The following is a description of a gene set: studied in species Homo sapiens part of: Innate Immune System Reactome Pathway: Fc epsilon receptor (FCERI) signaling Mast cells (MC) are distributed in tissues throughout the human body and have long been recognized as key cells of type I hypersensitivity reactions. They also play important roles in inflammatory and immediate allergic reactions. Activation through FCERI-bound antigen-specific IgE causes release of potent inflammatory mediators, such as histamine, proteases, chemotactic factors, cytokines and metabolites of arachidonic acid that act on the vasculature, smooth muscle, connective tissue, mucous glands and inflammatory cells (Borish & Joseph 1992, Amin 2012, Metcalfe et al. 1993). FCERI is a multimeric cell-surface receptor that binds the Fc fragment of IgE with high affinity. On mast cells and basophils FCERI exists as a tetrameric complex consisting of one alpha-chain, one beta-chain, and two disulfide-bonded gamma-chains, and on dendritic cells, Langerhans cells, macrophages, and eosinophils it exists as a trimeric complex with one alpha-chain and two disulfide-bonded gamma-chains. FCERI signaling in mast cells includes a network of signaling molecules and adaptor proteins. These molecules coordinate ultimately leading to effects on degranulation, eicosanoid production, and cytokine and chemokine production and cell migration and adhesion, growth and survival.<br>The first step in FCERI signaling is the phosphorylation of the tyrosine residues in the ITAM of both the beta and the gamma subunits of the FCERI by LYN, which is bound to the FCERI beta-chain. The phosphorylated ITAM then recruits the protein tyrosine kinase SYK (spleen tyrosine kinase) which then phosphorylates the adaptor protein LAT. Phosphorylated LAT (linker for activation of T cells) acts as a scaffolding protein and recruits other cytosolic adaptor molecules GRB2 (growth-factor-receptor-bound protein 2), GADS (GRB2-related adaptor protein), SHC (SRC homology 2 (SH2)-domain-containing transforming protein C) and SLP76 (SH2-domain-containing leukocyte protein of 76 kDa), as well as the exchange factors and adaptor molecules VAV and SOS (son of sevenless homologue), and the signalling enzyme phospholipase C gamma1 (PLC-gamma1). Tyrosoine phosphorylation of enzymes and adaptors, including VAV, SHC GRB2 and SOS stimulate small GTPases such as RAC, RAS and RAF. These pathways lead to activation of the ERK, JNK and p38 MAP kinases, histamine release and cytokine production. FCERI activation also triggers the phosphorylation of PLC-gamma which upon membrane localisation hydrolyse PIP2 to form IP3 and 1,2-diacylglycerol (DAG) - second messengers that release Ca2+ from internal stores and activate PKC, respectively. Degranulation or histamine release follows the activation of PLC-gamma and protein kinase C (PKC) and the increased mobilization of calcium (Ca2+). Receptor aggregation also results in the phosphorylation of adaptor protein NTAL/LAT2 which then recruits GAB2. PI3K associates with phosphorylated GAB2 and catalyses the formation of PIP3 in the membrane, which attracts many PH domain proteins like BTK, PLC-gamma, AKT and PDK. PI3K mediated activation of AKT then regulate the mast cell proliferation, development and survival., and this is the list of marker genes: SKP1, PSMC1, IGHV3-7, UBE2D1, MAP2K7, AHCYL1, IGLV1-36, TAB3, IKBKG, IGLV7-43, PSMD6, RAC1, TAB2, FYN, SEM1, UBE2D2, IGLV10-54, PPP3R1, SHC1, IGKV2D-40, IGHV3-13, PIK3CB, IGHV3-48, NFATC3, IGHV3-9, IGLV1-47, IGKV1-5, UBB, UBE2N, FOS, IGHV4-59, CHUK, TEC, IGHV4-39, IGKV2D-30, PSMD11 (NCBI Gene Id 5717), PSMC3 (proteasome 26S subunit, ATPase 3), ITK, PSMD12, PSMA6, RASGRP4, IGLV2-8, IGKV3-11, IGHV1-2, MAPK1, IGLV4-60, ADRM1, CDC34, IGHV, VAV2, TXK, PSMA7, IGKV4-1, PSMB6 (proteasome 20S subunit beta 6), VAV1, PSMD3, IGLC3, PSMD7, IGHV3-53, JUN, IGLV2-11, MAPK9, CARD11, IGHV2-70, IGKV1-12, PLCG2, IGLV2-18, IGLV3-12, IGLV2-14, PSMB3 (NCBI Gene Id 5691), NRAS, PSMD13, PSMB7, RELA, IGLV11-55 (NCBI Gene Id 28770), GRB2, ITPR3, PSMB4, IGLV1-51, IGHV7-81, RASGRP1, IGLC1, MAPK3, IGKV2D-28, IGLV4-3, IKBKB, TRAF6, RASGRP2, VAV3, PSMD1, IGKV1-16, PSMD14, PIK3R1, NFATC2, IGLC2, IGLV3-25, IGLV5-45, PAK2, PPP3CB, PRKCQ, FCER1A, MAP2K4, IGLV3-21, PSMD2, IGLV1-44, NFATC1, IGLV1-40, SOS1, MAP3K1, IGKV3-15, MALT1, PSMC5, GAB2, BTK, LAT, FBXW11, KRAS, IGKV2-28, IGLV3-27, IGLV4-69, CUL1, PIK3R2, IGHV3-30, MS4A2, ITPR2, IGKV1D-33, PSMA5, TAB1, FCER1G, GRAP2 (GRB2 related adaptor protein 2), RPS27A, IGHV3-11, SYK, PIK3CA, IGHE, IGKV3-20, PAK1, UBA52, IGKV1D-16, IGHV1-46, IGLC7, PSMD8, IGLV3-19, PSMB1, IGKV1D-12, IGKV1D-39, PSMC6, PSMB2, NFKB1, IGLV3-1, LCP2, IGKC, IGLV, IGKV3D-20, PSMA4, UBE2V1, IGHV2-5, IGLV6-57, IGLV7-46, PSMC4, IGKV1-17, MAPK10, BCL10, ITPR1, PLCG1, MAP3K7, IGKV2-29, IGLV2-33, PPP3CA, IGKV2-30, PSMC2, IGKV1-33, UBC, IGLV3-16, IGLV3-22, IGLV5-37, IGHV3-23, LAT2, IGLV2-23, PSMA1, PSMA2, HRAS, IGHV4-34, CALM1, IGKV1-39, PSMA3, PSMB5, LYN, IGHV3-33, IGLC6, MAPK8, NFKBIA, IGHV1-69, IGKV5-2, PDPK1, BTRC, IGLV8-61